The following is a description of a gene set: studied in species Mus musculus Mouse Gene Set: GOBP_REGULATION_OF_TRIGLYCERIDE_BIOSYNTHETIC_PROCESS Any process that modulates the rate, frequency, or extent of triglyceride biosynthesis. Triglyceride biosynthesis is the collection of chemical reactions and pathways resulting in the formation of triglyceride, any triester of glycerol., and this is the list of marker genes: Ldlr, Ctdnep1, Srebf1, Nr1h3, Dgat2, Sirt1, Kat5, Slc27a1, Nr1h2, Plin5, Rgn, Gpld1, Dgat1, C3, Gpam, Nr1h4, Mfsd2a, Apoc3, Cnep1r1, Sik1, Thrsp, Acsl5, Tmx1, Scarb1, Tcf7l2